The following is a description of a gene set: Human Gene Set: GSE1112_OT1_CD8AB_VS_HY_CD8AA_THYMOCYTE_RTOC_CULTURE_DN species: Homo sapiens Four independent chip hybridization with RNAs from four independent RTOC cultures. Genes down-regulated in CD8 alphabeta OT1 thymocyte RTOC culture versus CD8 alphaalpha HY thymocyte RTOC culture. from publication Yamagata T, Mathis D, Benoist C (PMID 15133507), and this is the list of marker genes: AVPR1A, HLTF, GTF3C4, ZNF586, PPP1R8, FIZ1, MMGT1, B2M, ZBED5, CT83, ZNF831, CLASP2, APOL6, TEX48, GABPB1, JPH3, NBEAP1, NARS2, SATB2-AS1, PIK3CA, ARPP19, COQ5, GCM2, NLRP7, PRPS2, RAB11FIP1, SNX14, PPP4R3A, SLC39A9, PDZD8, C15orf62, POSTN, NDUFA10, ZNF518B, SPAAR, ABHD14B, IL1RL1, IL9, MGA, S100A13, DSC1, HCG11, DRP2, NCOA7, UBE2U, CABCOCO1, MZT1, SLC16A1 (NCBI Gene Id 6566), ZFPM2, REPS1, DHH, SECISBP2L, DNM3OS, DCLK1, TASOR, UCHL5, RAB8B, SLC6A18, LINC01587, MAN1A2, ZBTB6, EDNRA, RAB28P5, PRPF39, PRRG4, LAMP2, IQCK, MAP4K5, ARMC8, VPREB1, UBR5, FAM83B, SLC25A35, EXD1, FGF21, PYCR3, LINC00887, OR52A1, LINC00477, CALU, TRBV27, GDI2, RRS1-DT, CANX, KHDC1, PTPRM, SYT6, HNRNPF, PPP4C, NGEF, CCDC138, ADNP, TLE3, SOCS2, C6orf62, ACLY, BCL11B, UBE2N (NCBI Gene Id 7334), TTC13, BOD1L1, ZNF202, GPR174, OPTC, TRPM7, ANGPTL1, PRMT6, RIT2, GAPT, PELI2, NPY2R, SLC39A7, WBP2NL, PGGT1B, NTAQ1, TMEM135, CEPT1, ARSK, HOXC12, KIR3DL1, COMMD10, KRTAP3-2, CEP97, SLC17A8 (NCBI Gene Id 64944), CDC37L1, DMBX1, IGLJ3, FLCN, KRTAP1-1, CNKSR2, GLYCTK, GABRG3 (gamma-aminobutyric acid type A receptor subunit gamma3), FAM47B, CFHR4, TMEM161B-DT, ZNF549, TENT5D, TRPC5, INSC (INSC spindle orientation adaptor protein), PDCD4, ANKRD13C, TARP, ITGB3, NKAPD1, CEP41, SDC3, GRPEL2, LINC00700, TMEM39A, NFXL1, IFT140, HNRNPK, AKAP11, COLEC12, MOB1B, BCORP1, NFYA, PCDH15, TRPC1, CRISP2, ZNF322P1, LINC01973, SRRM1, FUBP1, SPMIP4, RNF10, ENO2 (enolase 2), TTLL7, SMCHD1, RIMS4, OR7E87P, EAF1, CWH43, YWHAZ, MIPEP, MISP3, SLC25A13, PHOSPHO2, MRGPRX1, MED7, DYNLT5, TOX2, MAMLD1, C19orf47, TRIP12, DENND11, CNTNAP5, SAR1A, MTERF4, KIRREL3-AS3, ADPRHL1 (NCBI Gene Id 400169), TAS2R40, FADS2 (fatty acid desaturase 2), USP25, SLC2A12, UPK1B